Given this list of marker genes LUC7L3, PALS2, SPAST, KLHDC2, CLCN3, TRIM41, BACH2 (NCBI Gene Id 653980), CXXC5, ASF1A, NUBPL, RC3H1, LIMD2, CYTIP, ZNF131, AMPD1, FILIP1L, UBR2, ABCB7, SLC35B3, ZNF329, MTF2, TMEM33, SATB1, TULP3, CEPT1, CD164, SMARCC1, SETD6, TRIM59, RELCH, SMIM14, TENT4B (NCBI Gene Id 64282), IFT80, GPHN, AMPD3, KLHL24, LAMTOR3, PRMT6, OGT, XPO7, CBX3, CAMKK2 (NCBI Gene Id 121657), TXNDC15, COX11, GPBP1, CFL1, ZMYND11, NT5C3A (5'-nucleotidase, cytosolic IIIA), NEMP1, ST6GAL1, TUBB2A, TMEM161B, ABCD3, NAB2, DGKD, FAM91A1, WASL (NCBI Gene Id 8976), RTP4, PARP14, G2E3, ACO1, GABPA, MTAP, EMC6, LACTB, APPL2, IBTK, SQLE, XPOT, CDCA4, CD2AP, TTC13 (tetratricopeptide repeat domain 13), SPCS3, SMAD4, IDI1, JTB, STEEP1, SF3B2, ACAP2, RBM7, NPAT, SMC5, SMARCD2, ACTL6A, UNC50, POLG2, RAB14, GPRASP3, GTPBP2, RAD21, MATR3, SMC4, TNIK, TOMM20, ST8SIA1, RASGRP1, TRIM27, SET, TMEM71 (transmembrane protein 71), SNRPA1, MPHOSPH8, JARID2, ZNF157, PABPN1, PARP9, CCR9, TDP2 (NCBI Gene Id 51567), TPRG1L, C1orf52, HIPK3, SLC25A36, NAE1, SRRM1, APPL1, SOD2, GGA2, FRMD4A, TMEM165, FLVCR1, NCOA2, TMEM50B, TRMT6, DBR1, CASD1, RESF1, RRM2B, METTL9, EPS15, CHM, RSAD2 (NCBI Gene Id 91543), IFT25, TMEM131, ZFP82, NGLY1, SBK1, GET4, PIK3IP1, PPM1K, ZNF384, BCL2L11, RFX7, RASGRF2, GCSH, RBM12, DNAJC5, ICE2, ADNP, TRIM56, TRAT1, BCL2L13, EID1, REV3L, KDM1B, OPA1, HNRNPK, SLC49A4, ZRANB2, ZFYVE16, API5, TRAF3, PTCH1, HOOK1, RPL23, PARD6G, MINDY2, EZH2, ACTR6, DHX15, USP1, SMIM15, PEX11A, RNF19A, PPP1CC, GLRX2, MTURN, TAF2, CLNS1A, CCDC171, PRKD3, SPRED2, PDE7A, LIN9, KBTBD7, NUP62, QRSL1, ACSL3, PPIC, POGZ, WDR26, FBXO9, HAPSTR1, SLC35E2B, C21orf91, VPS4B (NCBI Gene Id 9525), MFF, ACVR1B, NDRG1, RAB2B, EGR2, ABTB1, here is a description of the gene set: from publication Sarkar S, Kalia V, Haining WN, Konieczny BT, Subramaniam S, Ahmed R (PMID 18316415) Genes up-regulated in comparison of naive CD8 T cells versus memory CD8 T cells. species: Homo sapiens Using killer cell lectin-like receptor G1 as a marker to distinguish terminal effector cells from memory precursors, we found that despite their diverse cell fates both subsets possessed remarkably similar gene expression profiles and functioned as equally potent killer cells. However, only the memory precursors were capable of making IL-2 thus defining a novel effector cell that was cytotoxic, expressed granzyme B, and produced inflammatory cytokines in addition to IL-2. This effector population then differentiated into long-lived protective memory T cells capable of self-renewal and rapid re-call responses. Mechanistic studies showed that cells that continued to receive antigenic stimulation during the later stages of infection were more likely to become terminal effectors. Importantly, curtailing antigenic stimulation towards the tail-end of the acute infection enhanced the generation of memory cells. These studies support the decreasing potential model of memory differentiation and show that the duration of antigenic stimulation is a critical regulator of memory formation Human Gene Set: GSE10239_NAIVE_VS_MEMORY_CD8_TCELL_UP